The following is a description of a gene set: part of: Inflammasomes species: Homo sapiens The IPAF (NLRC4) inflammasome can be activated by several stimuli, most notably by Gram-negative bacteria with either type III or type IV secretion systems that result in cytosolic flagellin, which is recognized by the IPAF inflammasome. IPAF also recognizes the rod-component of the type III secretion system which shares a sequence motif with flagellin that is essential for detection. Detection of Legionella and/or flagellin may also involve NAIP5. IPAF contains a CARD domain and can interact directly with procaspase-1 but ASC increases the maximal activation of caspase-1 in response to S. typhimurium, S. flexneri, and P. aeruginosa suggesting a possible collaboration with a PYD-containing NLRP for responses to these pathogens (Schroder & Tschopp, 2010). IPAF mediated caspase-1 activation can lead to a particular type of cell death called 'pyroptosis' (see Schroder & Tschopp 2010). Reactome Pathway: The IPAF inflammasome, and this is the list of marker genes: fliC, NLRC4, CASP1, fljB, prgJ